Given this list of marker genes Gm11801, Gm24125, Gm11784, Gm11840, Vmn1r2, Tox, Gm11832, Gm11810, Gm11830, Asph, Gdf6, Gm12920, Vmn1r3, Gm24152, Lrrc69, Gm11816, Rps18-ps2, 1700120G11Rik, 4930430E12Rik, Triqk, Fsbp, Gm11847, Virma, Gm11805, Vmn1r-ps2, Slc26a7, Gm11799, Gm23860, Uba52rt, 2210414B05Rik, 4930448K20Rik, Gm11809, Plekhf2, Car8, Chchd7, Gm24068, Plag1, Lyn, Gm11783, Gm11821, Gm11796, Pip4p2, Penk, 4930412C18Rik, Gm24337, Gm11826, Ubxn2b, Gm11836, Gm26436 (predicted gene, 26436), Rbm12b2, Gm11786, Gm11779, Gm22473, Fam110b, Ccne2, Gm11803, Mir684-2, Gm11787, Gm11841, Gm11824, Rps20, Gm11833, Gm22781, Gm12918, Gm11804, Gm24908, Chd7 (NCBI Gene Id 57137), Ints8, Rab2a (NCBI Gene Id 93773), 1700123M08Rik, Mos, A830012C17Rik, Vmn1r-ps3, Tmem68, Esrp1, Dpy19l4, Gm11797, Rbm12b1, Gm11839, Gm11820, Gm12919, Gm11823, Pdp1, Cibar1, Rps10-ps3, Gm11780, Gm11827, Rps11-ps3, Mir3471-2, 8430436N08Rik (NCBI Gene Id 71510), Sdr16c5 (short chain dehydrogenase/reductase family 16C, member 5), Gm11802, Sdr16c6, Mir3471-1, Tmem67, Cfap418, Clvs1, Rad54b, Bpnt2, Ndufaf6, Nsmaf, Gem, Otud6b, Gm23423, Gm24016, Sdcbp, 1700123O12Rik, Runx1t1, Cyp7a1, Gm11843, 4930423M02Rik, Gm11814, Gm11829, Trp53inp1, Cdh17, Tgs1, here is a description of the gene set: studied in species Mus musculus Mouse Gene Set: chr4A1